The following is a description of a gene set: species: Mus musculus Human Gene Set: BOYLAN_MULTIPLE_MYELOMA_C_UP from publication Boylan KL, Gosse MA, Staggs SE, Janz S, Grindle S, Kansas GS, Van Ness BG (PMID 17483317) Multiple myeloma is an incurable plasma cell malignancy for which existing animal models are limited. We have previously shown that the targeted expression of the transgenes c-Myc and Bcl-X(L) in murine plasma cells produces malignancy that displays features of human myeloma, such as localization of tumor cells to the bone marrow and lytic bone lesions. We have isolated and characterized in vitro cultures and adoptive transfers of tumors from Bcl-xl/Myc transgenic mice. Tumors have a plasmablastic morphology and variable expression of CD138, CD45, CD38, and CD19. Spectral karyotyping analysis of metaphase chromosomes from primary tumor cell cultures shows that the Bcl-xl/Myc tumors contain a variety of chromosomal abnormalities, including trisomies, translocations, and deletions. The most frequently aberrant chromosomes are 12 and 16. Three sites for recurring translocations were also identified on chromosomes 4D, 12F, and 16C. Gene expression profiling was used to identify differences in gene expression between tumor cells and normal plasma cells (NPC) and to cluster the tumors into two groups (tumor groups C and D), with distinct gene expression profiles. Four hundred and ninety-five genes were significantly different between both tumor groups and NPCs, whereas genes were uniquely different from NPCs in tumor group C and genes were uniquely different from NPCs in tumor group D. Similar to human myeloma, the cyclin D genes are differentially dysregulated in the mouse tumor groups. These data suggest the Bcl-xl/Myc tumors are similar to a subset of plasmablastic human myelomas and provide insight into the specific genes and pathways underlying the human disease. Genes up-regulated in group C of tumors arising from overexpression of BCL2L1 and MYC in plasma cells., and this is the list of marker genes: GAS5, LRIG1 (NCBI Gene Id 26018), NASP, LGR5, PDE2A, CPSF6, LPCAT1, STX2, PPM1F, CAD, ETS1 (ETS proto-oncogene 1, transcription factor), MTOR, APOBEC2, FOXP4, DYRK2, ZBED4, ANGPTL4, ZFPM1, FAM13A, DHX38, RLIM, NFYA, ARVCF, ASB2, FAM53B, FKBP3, RBKS, SPIB, PTER, DPP4, EBF1, JCAD, MCM3, SMTNL2, VPREB3, EMID1, CARMIL1, SKP2, TYMS, CSTF1, HEATR1, FAM110A, ZMYND19, PTGR1, MARCKSL1, PRM1, CLIP1, HNRNPD